The following is a description of a gene set: Mouse Gene Set: GOBP_REGULATION_OF_T_HELPER_1_TYPE_IMMUNE_RESPONSE studied in species Mus musculus Any process that modulates the frequency, rate, or extent of a T-helper 1 type immune response., and this is the list of marker genes: Anxa1, Nlrp10, Ccr7, Tbx21, Il4ra, Slamf1, Il1rl1, Irf1, Slc11a1, Il23a, Tnfsf4, Ccr2, Il1b, Il1r1, Il33, Il18, Il23r, Il27, Socs5, Il27ra, Il12rb1, Arid5a, Pla2g4a (NCBI Gene Id 226493), Ascl2, Il12b, Il18r1, Xcl1, Ccl19, Jak3, Ripk2, Havcr2, Hlx